Given this list of marker genes IWS1, RHOH (NCBI Gene Id 399), SLC25A27, PGAM5, HAUS3, ARL10, TUBB2A, MRM2, TCTA, PDGFD, HEMK1, VHL, COMMD10, SLFN12L, MESD, ALKBH1, ABCC2, SLC16A1 (NCBI Gene Id 6566), GUF1, MFAP1, EEF1B2, SLC44A2, DZIP1, TRIB3, NAA30, NFS1, TENT5C, RPS23, NPRL2, LEF1, OTC, FBXL12, UPF2, ZNF846, ATF2, MR1, LIG4, TIMM29, TAFAZZIN, USP30, DPP7, PAPOLG, ZNF383, MED22, FANCG, MICALL2, BTG2, MRPL19, SCAPER, B3GNT8, PITHD1, ALKBH4, OFD1, C12orf56, ABHD15, N4BP3, PIGH, LCOR, SIRT3, ERC2, TEC, DNAAF9, DAGLB, CUL4B (NCBI Gene Id 8450), TAF15, MYLIP, TMEM128, FLT3LG, RIOX2, PLS3, CXCR4, KRTAP8-1, ZYG11B, LUC7L3, ANAPC16, PIK3IP1 (NCBI Gene Id 113791), DR1, UQCC1, CCR7, PSMA6, COX15, TP53INP1, CIB1, SNHG12, SNX2, ADSS2, PDRG1, STAG1, PPCS, TMEM18, STK39, LGALS8, TIMM21 (translocase of inner mitochondrial membrane 21), ZNF708, HARS2, TTLL12, TMEM106B, THOC5, DGKE, CDK20, BACH1, HDHD5, FUCA2, UTS2R, PDZD11, SNRPB2, NFKBIE, SOCS3, JADE3, CLTC, SMYD1, ZZZ3, CTSV, GCSH, OTUD1, PPIL4, FBLN2, MAF1, LANCL1, ANKRD46, TXNIP, ZFX, PSME3IP1, HGH1, CDKL1, IFT70B, PTGR3, HMGA2, PAICS, CBX5, TASOR2, NEU3, CLDN4, CCDC171, RASEF, TIPARP, NFKBIA, FLCN, PPIC, ERICH3, MZT1, RAG2, CERS3, SLC35B4, NUDT16, GALNS, DDX28, ATF7IP2, DCAF11, TFAM, RDH14, KIAA0753, NKAP, RABGGTB, ZBTB44, RTN4, FGFR1OP2, RAG1, ZNF654, TMEM186, PSIP1, DDB2, CNP, CDK19, FBXO38, DYRK2, KDM4A, ZNF346, PNN, SLC35E3, ARMC7, MBD2, CSTF1, WDR82, DDIT4, SREK1IP1, VCPKMT, CDC27, RAD52, CCDC71L, AP2A2, GCDH, ELP6, ATG12, PSMG3, METTL17, KLHL7, BLCAP, TIA1, ATAD2B (NCBI Gene Id 54454), TSR1, LAIR1, CCNQ (cyclin Q), GJA4, CASP2, ERRFI1, CHCHD7, UBOX5, RAPGEF3, FBXL5, here is a description of the gene set: Microarrays of gene expression in mouse germinal center B cells photoactivated in the light zone or dark zone, and of naïve cells for comparison. We used microarray data to identify genes differentially expressed by B cells in the light and dark zones of the germinal center. Genes down-regulated in B cells: light zone versus naïve. from publication Victora GD, Schwickert TA, Fooksman DR, Kamphorst AO, Meyer-Hermann M, Dustin ML, Nussenzweig MC (PMID 21074050) studied in species Homo sapiens Human Gene Set: GSE23925_LIGHT_ZONE_VS_NAIVE_BCELL_DN